Given this list of marker genes Pgam1, Mettl1, Cox17, Sdad1, Cmpk1, G3bp1, C1qbp, Slc33a1, Mrto4, Mgl2, S100a4, Pfdn4, Mrps25, Dkc1, Cacybp, Ciita, Jpt1, Ppp1r18, Cd207, Cish, Lcp1 (lymphocyte cytosolic protein 1), Eif4a1, Emg1, Gng5, Ewsr1, Card19, Pfdn6, Uchl3, Qpct, Bccip, Fkbp5, Srp9, Ywhaz, Dynlrb1, Uap1l1, Gart, Tes, Vta1, Tgfb1, Snx3, Mrpl12, Serpina3g, Arl8b, Snrnp27, Psmc5, Sfxn1, Cd53, Gnb4, Dcun1d5 (defective in cullin neddylation 1 domain containing 5), Odc1, Elovl5, Eno1, Btla, Basp1, Casp8, Ccl17, Rab14, Eml4, Bcl2a1a, Ywhab, Asb2, Nop56, Ostc, Orai1, Srgn, Nhp2, Psmb8, E2f5, Hnrnpll, Ccdc86, Fth1, Grk2, Ncl, Hspa8, Clec10a, Litaf, Ccnd2, Vrk1, Nsfl1c, Pacsin2, Bcl2a1b, Prdx1, Mboat1, Cdkn1a (cyclin dependent kinase inhibitor 1A), Actr3, Eif6, Bcl2a1d, Arf1, Nptn, Gtpbp4, Snrpd1, Ifi205, Ccnd3, Nolc1, Coro2a, Ifi35, Aco2, Nfkb1, Rara, Ms4a6d, Magt1, Pfdn2, Rrp9, Syncrip, Adpgk, Nme1, Runx1, Hdlbp, Mical1, Emc8, Fcrla, Spi1, Hnrnpu, Psmd14 (NCBI Gene Id 98839, proteasome (prosome, macropain) 26S subunit, non-ATPase, 14), Idh3a, Ndufb6, Spint1, Prelid1, Hsp90aa1, Rrp15, Rac1, Pim1, Cbfa2t3, Eif4ebp1, Pip4k2a, Pfn1, Tomm5, Cct3, Lims1, Mtss1, Ndufab1, Rnps1, Puf60, Eef1e1, Ndufa12, Hnrnpab, Cyp4f16, Emc6, Eny2, Itgae, Plpp1, Dnaja1, Notch4, Lgals3 (lectin, galactose binding, soluble 3), Myl12a, Prmt1, Gnl3, Twf2, Metap2, Anks3, Agps, Trio, Reep3, Calm1, Mybbp1a, Hsbp1, Eif5a, Tpm3, Clns1a, Alyref, H2-DMb1, Vapa, Parl, Tubb4b, Cnn2, Srm, Gnb2, Rwdd1, Efhd2, Ppan, Armc8, Gspt1, Rap2a, Srsf7, Cct5, Cd300a, Ddx21, Ube2e1, Pdia6, Psme2 (proteasome (prosome, macropain) activator subunit 2 (PA28 beta)), Dapk1, S100a13, Psmd6, Eif4e, Mrpl38, Exosc1, Cst3 (cystatin C), Gar1, Znhit6, Cnbp, Sec61g, Tbcb, Tnfrsf13b, Serbp1, Cd209a, Lap3, Ptpn1, Ctsz, Timm17a, Glrx5, Eif2s1, Srsf3, Cstb, Sdhc, Esyt2, H2-DMb2, Prpf31, Eif1ax, Atp5f1b, Socs1, Ece1, Grb2 (NCBI Gene Id 14784), Prkcd, Fkbp1a, Hspa9, Etfa, Phb1, Nip7, Rbx1, Ube2s, Macroh2a1, Id2, Ppp1r14b, Napsa, Atp5mc1, Ruvbl1, Anxa2, Psma7, Ppa1, Ccnd1, Ccdc115, F2rl2, Ppm1m, Pes1, Dnajc2, Plbd1, Timm13, Mydgf, Naaa, Mif, Snu13, Uck2, Eif1ad, Sin3b, Serp1, Tagln2, Dnaja2, Morf4l2, Pfkp, Sell, Bud23, Snrpa1, Rpf2, Ddx39a, Septin3, Cndp2, Plek, Ccl12, Pnp, Mrps28, Stard3nl (NCBI Gene Id 76205), Llph, Set, Zyx, Cox8a, Plgrkt, Rars1, Akt1, Slco3a1, Creld2 (cysteine-rich with EGF-like domains 2), Cyrib, Nrros (NCBI Gene Id 224109), Dynll1, St3gal4, Denr, Ybx3, S100a6, Mrpl54, Calm2, Lta4h, Plet1, Ran, Aen, Nlrp3, Nop58, Ssr2 (signal sequence receptor, beta), Slfn2, Myd88, Fcgrt, Tram1, Ost4, Cfl1, Lgals1, Cct8, Psmb6, Cd9, Uqcrc1, Rexo2, Hspd1, Rpn1, Hspa4, Ywhae, Kmo, Lrba, Hnrnpk, Med21, Nifk, Fh1, Chd7, Hnrnpa3, Kif5b, Nop16, Cox5a, Ctu2, Hnrnpf, Mkrn1, Tpm4, Ldha (lactate dehydrogenase A), Mat2a, Psma3, Vasp, Mrpl20, Fkbp4, Prex1, Ywhag, Sirt2, Srsf2, Gtf3c6, Olfm1, Pcbp1, Irf5, Aimp2, Arpc5, Cycs, here is a description of the gene set: from publication Cui A, Huang T, Li S, Ma A, Pérez JL, Sander C, Keskin DB, Wu CJ, Fraenkel E, Hacohen N (PMID 38057668) studied in species Mus musculus Genes positively differentially expressed in cell type: cDC1 (conventional dendritic cell type 1) upon treatment with cytokine: GM-CSF in mouse lymph nodes in vivo. Mouse Gene Set: CUI_CDC1_GM_CSF_RESPONSE_UP Cytokines mediate cell-cell communication in the immune system and represent important therapeutic targets. A myriad of studies have highlighted their central role in immune function, yet we lack a global view of the cellular responses of each immune cell type to each cytokine. To address this gap, the authors created the Immune Dictionary, a compendium of single-cell transcriptomic profiles of more than 17 immune cell types in response to each of 86 cytokines (>1,400 cytokine-cell type combinations) in mouse lymph nodes in vivo. A cytokine-centric view of the dictionary revealed that most cytokines induce highly cell-type-specific responses. For example, the inflammatory cytokine interleukin-1β induces distinct gene programmes in almost every cell type. A cell-type-centric view of the dictionary identified more than 66 cytokine-driven cellular polarization states across immune cell types, including previously uncharacterized states such as an interleukin-18-induced polyfunctional natural killer cell state.